The following is a description of a gene set: Midline defect of the nose This term groups together three conditions that presumably represent different degrees of severity of a midline defect of the nose or nasal tip. species: Homo sapiens Human Gene Set: HP_MIDLINE_DEFECT_OF_THE_NOSE, and this is the list of marker genes: EFNB1, FREM1, FREM2, ALX1, ZSWIM6, NUAK2, ALX3, ALX4, GRIP1, NSMF, LONP1, TFE3, HYLS1, PTCH1, TBX4, FRAS1 (Fraser extracellular matrix complex subunit 1), NF1